The following is a description of a gene set: species: Mus musculus Mouse Gene Set: GOBP_T_CELL_CHEMOTAXIS The directed movement of a T cell in response to an external stimulus. A T cell is a type of lymphocyte whose defining characteristic is the expression of a T cell receptor complex., and this is the list of marker genes: Cxcr3, Wnk1, Xcl1 (chemokine (C motif) ligand 1), Adam17, Oxsr1, Ccl26, Cxcl13, Cxcl12, Tmem102, Slc12a2, Gpr183, Ccr2, Wnt5a, Tnfsf14, Plec, Lgals9, Cxcl11, Stk39, Ccl3, Ccr7, Cxcl16, Cxcl10, Ccl21a, Adam10, Ccl5